Given this list of marker genes METTL9, CCR7, PRKD2, FARSB, TTC14, BTBD1, AKR1C4, MPHOSPH9, WFS1, ZFAND5, MYB, CD5, DCP1A, SPTBN1, RBX1, PLAUR, BIRC3, ZNRF1, IFI27L2, RGCC, RAB3IP, BLK, MAP4K2, AKAP9, RPS8, NAB2, CANX, DNAJC7, CD8A, UBE2R2, JARID2, RNF14, PIP4K2A, HDAC1, MS4A1, ULK1, LAT2, ZFP1, TIA1, ATP5IF1, CD1D, MBTD1, RAMP1, DLG3, PPIC, IFIT1B, MTF2, PAN2, PRKCB, NASP, IL6R, MECR, PWP1, CASK, ORC4, RGS7, HBS1L, TWSG1, IGF1R, MRM3, USP34, SESN1, IKBKE, TCP11, ITGAE, CCR9, INTS14, NUDT16L1, HLA-DOA, CTSV, POU2AF1, DNTT, CD19, RPS6KA2, NEDD9, HLA-DOB, CRAMP1, KMT2A, HDAC2, OXCT1, GRK6, FNTA, SFXN2, NCBP1, DDX50, ZPBP, TCF4, TNNT1, SPCS2, ETS2, FKBP4, NDRG1, CYB5A (cytochrome b5 type A), CLK4, MFHAS1, ID3, SFMBT2, ACADM, KCNA3, MRPL37, ISG20, IRF9, DCK, PSAP, PDK1, STT3B, CSNK1E, GABRR2, ABCG2, ADCY7, GGT5, DDIT4, QRICH1, EXT1, BIRC2, MUC13, NRIP1, SMC4, BRD7, EGR2, MIOS, NSMCE1, TMEM245, IDH2, IGHM, RNASET2, P2RX4, EML5, TUBA1A, TTC3, MPP1, ANAPC5, S100PBP, ZNF292, ADCY6, KANSL2, ST6GAL1, SEC11C, RALGPS2, DUSP6, NSG2, HDLBP, CNN3, EPHX1, CTSS, CCDC93, RPF1, GRIA3, SLC25A14, LAPTM4B, RETREG1, ABLIM1, SQLE, DDX6, DDC, RFLNB, ENG, PLEKHA1, PHTF2, TMEM50B, ANP32A, PSMA5, C3AR1, TDRP, CD9, CXXC5, POLR3A, WDR26 (NCBI Gene Id 80232), GPD2, CYTH3, TNFAIP8L1, SRM, NRAS, ZNF281, MAP7, IL6ST, UGCG, KIF23, LIPA, PBX2, LDLR, CSAD, CTPS1, TSPAN32, CDK2, BBS9, ACTN1, RWDD4, PIGX, TBCE, TMEM191C, DAP (NCBI Gene Id 1611), P4HA1, SPSB1, SLC30A4, KIT, TLR6, ZFR, SLC44A1, POU3F4, here is a description of the gene set: studied in species Homo sapiens CD8 T cells normally differentiate from resting naïve T cells into function effector and then memory CD8 T cells following acute infections. During chronic viral infections, however, virus-specific CD8 T cells often become exhausted. We used microarrays to examine the gene expression differences between naive, effector, memory and exhausted virus-specific CD8 T cells following lymphocytic choriomeningitis virus infection. Genes up-regulated in comparison of naive CD8 T cells versus memory CD8 T cells. Human Gene Set: GSE9650_NAIVE_VS_MEMORY_CD8_TCELL_UP from publication Wherry EJ, Ha SJ, Kaech SM, Haining WN, Sarkar S, Kalia V, Subramaniam S, Blattman JN, Barber DL, Ahmed R (PMID 17950003)